The following is a description of a gene set: species: Mus musculus Mouse Gene Set: GOBP_CELL_VOLUME_HOMEOSTASIS Any process involved in maintaining the steady state of a cell's volume. The cell's volume refers to the three-dimensional space occupied by a cell., and this is the list of marker genes: Aqp11, Aqp1, Slc12a6, Add1, Lrrc8a, Sct, Gnb3, Oxsr1, Slc12a5, Shank3, Slc12a8, Clns1a, Lrrc8e, Slc12a9, Anxa7, Aqp4, Kcnn4, Slc12a2, E2f4, Clcn3, Slc6a12, Ano6, Kcnma1, Wnk3 (NCBI Gene Id 546388), Slc12a7, Sctr, Wnk1, Abcb8, Slc12a1, Slc12a3, Ccdc51, Fshr, Gprc5b, Cln3, Aqp2, Stk39, Prkg2, P2rx7, Slc12a4, Npm1